Given this list of marker genes UBA52, MVB12A, RPS27A, VPS37B, VPS37C, UBAP1, NMT2, TSG101, VPS28, MVB12B, VPS37D, VPS37A (VPS37A subunit of ESCRT-I), UBC, gag, UBB, here is a description of the gene set: studied in species Homo sapiens One of the mysteries of Gag protein involvement in HIV virion assembly is how the proteins are targeted to the proper membrane for budding. Infectious retroviruses do not bud from all of the available membrane surfaces within an infected cell, but primarily from the plasma membrane, which constitutes a small proportion of the total membrane surface in most cells. In polarized cells, the sites of budding are further restricted to the basolateral membrane. part of: Synthesis And Processing Of GAG, GAGPOL Polyproteins Reactome Pathway: Membrane binding and targetting of GAG proteins